The following is a description of a gene set: Cells from four develppmental stages were purified by FACS from human bone marrow samples studied in species Homo sapiens Genes up-regulated during B lymphocyte differentiation: small pre-B II versus VPREB1+ large pre-B II. from publication Hoffmann R, Lottaz C, Kühne T, Rolink A, Melchers F (PMID 17890238) Human Gene Set: GSE4590_SMALL_VS_VPREB_POS_LARGE_PRE_BCELL_UP, and this is the list of marker genes: MBTD1, GTF2H2, BRD7, TBC1D19, AATF, AKAP9, FARS2, CACNB2, ANKS3, PHTF2, GGA2, MIR1-2, DOCK10, IFT57, QSER1, CCDC28A (NCBI Gene Id 25901), RALGAPA2, KCTD1 (potassium channel tetramerization domain containing 1), MVB12B, CD93, TAOK3, SNX30, CD200 (CD200 molecule), AIM2, RNF13, KBTBD3, EXOC6, ZBTB10, TET1, XKRX, PLOD2, ALPK1, RIMOC1, ST7L, CCDC125, PRKAR2B, GRIA3, TDRD5, WDFY4, UBE3C, DNAJA3, TTC1, GBE1, PRMT9 (NCBI Gene Id 90826), PECR, RICTOR, TDRD3, KIT, ITPR1, NEDD4, INTS4, KDM5B, ALCAM, PHF21A, FBXL20, NT5C2, OGT, PAN3, CALCRL (calcitonin receptor like receptor), KATNAL1, PARP8, IL27RA, NOL8, CIBAR1, VEZF1, ZBTB20, TIFA, OXCT1, CPT1A, PNPLA7, YLPM1, TCEAL8 (transcription elongation factor A like 8), NF1, INPP5K, FBXL12, EIF2AK4, VAMP7, PNPT1, KLF3, MLEC, PPP5C, NAF1, CCDC50, KIFAP3, DNTT, GTF2I, ARID4A, PLEKHA3, PRKAR2A, PITPNC1, THUMPD1, NOC4L, BRD9, CCDC91, FNDC3A, ASAH2, AMMECR1L (AMMECR1 like), DGKE, TRPS1, ICE2, TMEM176B, OSBPL1A, MEPCE, EIF3C, CUL1, FBXO27, PRR15, SLC12A2, ATP6V0B, GPR174, POU3F4, PTGER4, IQCB1, MCTS2, PLCB2, PRDM5, POLK (DNA polymerase kappa), FAM120C, ETV6, MAP4K4, CPNE2 (copine 2), LSM7, SPATA6, THOC5, ZFR, NR3C1 (NCBI Gene Id 389335), SVIL, DCTD, AFG3L2, MARVELD1 (NCBI Gene Id 83742), LUZP1, PRPS1L1, EFCAB7, THUMPD2, IGF1R, TOMM40, CAMSAP2, CCPG1, BAZ2B, PDK1, TERF2, NIT2, CUX1, ERLEC1, NCOA2, RGS18, DNAI4, SHPRH, METTL8, CCR9, ELP1, BCAP29, BRWD1, ACSL5, PDRG1, CHM, ZMYND8, ZFP36L2, LCLAT1, ZIK1, RNF216, IPCEF1, TSC22D1, PLAG1, KIAA1328, ASCC1, TCF4, S100G